The following is a description of a gene set: Mouse Gene Set: CUI_B_CELL_IL27_RESPONSE_UP from publication Cui A, Huang T, Li S, Ma A, Pérez JL, Sander C, Keskin DB, Wu CJ, Fraenkel E, Hacohen N (PMID 38057668) Cytokines mediate cell-cell communication in the immune system and represent important therapeutic targets. A myriad of studies have highlighted their central role in immune function, yet we lack a global view of the cellular responses of each immune cell type to each cytokine. To address this gap, the authors created the Immune Dictionary, a compendium of single-cell transcriptomic profiles of more than 17 immune cell types in response to each of 86 cytokines (>1,400 cytokine-cell type combinations) in mouse lymph nodes in vivo. A cytokine-centric view of the dictionary revealed that most cytokines induce highly cell-type-specific responses. For example, the inflammatory cytokine interleukin-1β induces distinct gene programmes in almost every cell type. A cell-type-centric view of the dictionary identified more than 66 cytokine-driven cellular polarization states across immune cell types, including previously uncharacterized states such as an interleukin-18-induced polyfunctional natural killer cell state. Genes positively differentially expressed in cell type: B cell upon treatment with cytokine: IL-27 in mouse lymph nodes in vivo. studied in species Mus musculus, and this is the list of marker genes: Psmb9, Plac8, Ms4a4c (membrane-spanning 4-domains, subfamily A, member 4C), H2-D1, Ly6a, Ifi47, Cd47, Stat1, Nosip, Gbp7, Ifi27l2a